The following is a description of a gene set: Intermittent claudication is a symptom of peripheral arterial occlusive disease. After having walked over a distance which is individually characteristic, the patients experience pain or cramps in the calves, feet or thighs which typically subsides on standing still. Human Gene Set: HP_INTERMITTENT_CLAUDICATION Intermittent claudication studied in species Homo sapiens, and this is the list of marker genes: XYLT1, NT5E, ABCC6, XYLT2, JAK2, ENPP1, HLA-B, MLX, AGXT, AEBP1, IL12B